Given this list of marker genes HYAL1, ACVR1, ZMPSTE24, LEMD3, TRPV4, LMNA, HNRNPA2B1, BSCL2, HNRNPA1, VCP, COL2A1, MATN3, here is a description of the gene set: Human Gene Set: HP_HIP_PAIN species: Homo sapiens Hip pain An unpleasant sensation characterized by physical discomfort (such as pricking, throbbing, or aching) localized to the hip.